The following is a description of a gene set: A transcription initiation process that takes place at a RNA polymerase II gene promoter. Messenger RNAs (mRNA) genes, as well as some non-coding RNAs, are transcribed by RNA polymerase II. studied in species Homo sapiens Human Gene Set: GOBP_TRANSCRIPTION_INITIATION_AT_RNA_POLYMERASE_II_PROMOTER, and this is the list of marker genes: KAT2B, TAF11L6, GTF2A1L, SUB1, E2F3 (E2F transcription factor 3), TET3, GTF2F2, MED30, GLYR1, GTF2E1, INTS2, KDM1A, MEN1, TP53, MED22, MED29, TAF11L2, ELOB, TAF11L10, E2F2, RBX1, FAM47E, DR1, POLR2I, MED6, PPP2CA, WNT10B, KMT2A, SMARCA4, SAMD1, CTNNBIP1, TAF11L8, SGF29, SMARCB1, GTF2A2, N6AMT1, HNF1B, MED1, ARID1B, MED20, INTS5, MED31, TAF5, RBBP5, MED21, ZNHIT1, VPS72, TRMT112, GTF2E2, TAF11L14, APOBEC3C, MED11, KAT7, MYC, INTS6, SRF, KAT8, TET1, TAF2, TBP, HNF1A, APOBEC2, ERCC6, EGR1, GTF2H1, TAF4B, TAF11L3, ATAD2B, INTS1, TAF3 (TATA-box binding protein associated factor 3), MAZ (MYC associated zinc finger protein), MED28, WDR5, INTS13, INTS3, L3MBTL3, INTS7, PPM1D, TET2, SIRT7, ERCC1, ZMPSTE24, WBP2, INTS15, TAF8, GTF2H5, ERCC3, TAF7, CCNH, MED24, MED12, GTF2B, TAF1L, INTS10, MED4, TAF11L13, TAF4, PADI2, MED26, TAF11L4 (TATA-box binding protein associated factor 11 like 4), TAF7L, TAF11L12, INTS9, INTS12, GTF2F1, ARMC5, NKX2-5, PSMC6, NFKBIA, EP300, GTF2A1, SMARCD1, INTS11 (NCBI Gene Id 84139), INTS4, MED16, TAF9, DHX36, ZNF451, MED19 (NCBI Gene Id 219541), SPI1, MED10, CDK7, FOXO1, THRA, DPY30, CDK4, POLR2D, CDK9, PAXIP1, MED18, MED25, TAF6, MED14, ASH2L, AICDA, CAND1, NFKB1, TAF10, NOC2L, TAF1, GTF2H2, PRMT3, ELOA, MED13, ELOC, CREB1, MACROH2A1, MED15, TAF11, APOBEC3F, TAF11L7, MED8, CTCFL, RBM14, OGG1, MED27, XPA, PWWP2A, ARID1A (NCBI Gene Id 8289), ATAD2, ERCC2, KDM1B, TAF6L, SPHK2, APEX1, PPP2R1A, MED17, TAF13, APOBEC1, PHF2, MED7, MYOCD, ATF2, INTS8, INTS14, POLR2G, MNAT1, HMGB1, TAF12, BRD7 (NCBI Gene Id 29117), TAF11L9, USP21, TAF11L11 (NCBI Gene Id 112488746), MED9, MED23, PAAF1, PPARGC1A, ESR1, APOBEC3A, HEY2